The following is a description of a gene set: Any apoptotic process in a smooth muscle cell. Smooth muscle consists of non-striated, elongated, spindle-shaped cell found lining the digestive tract, uterus, and blood vessels. Mouse Gene Set: GOBP_SMOOTH_MUSCLE_CELL_APOPTOTIC_PROCESS studied in species Mus musculus, and this is the list of marker genes: Arrb2, Gapdhrt2, Igf1, Apoh, Sirt1, E2f3, Dnmt1 (DNA methyltransferase 1), Sod2, Mapk7, Gapdhrt, Pparg, Nr4a3, Esr1, Cftr, Mfn2, Mir124a-1hg, Grp, Gsk3b, Agtr1a, Map2k4, Rbm10, Adcy10, Il12b, Lrp6 (low density lipoprotein receptor-related protein 6), Pde1a, Dipk2a, Pdcd4, Stk4, Slc7a5, Bag1, Gria4, Ifng, Il12a, Map2k5, Foxo1, Stub1, Cdkn2a, Lypd3, Gapdh, Atf4, Arrb1, Edn1